The following is a description of a gene set: from publication Chen Y, Wang X (PMID 31504780) Human Gene Set: MIR30E_3P Genes predicted to be targets of miRBase v22 microRNA hsa-miR-30e-3p in miRDB v6.0 with MirTarget v4 prediction scores > 80 (high confidence targets). species: Homo sapiens, and this is the list of marker genes: EMC4, P2RY1, RALGPS2, EGR1 (NCBI Gene Id 1958), NKRF, DIP2B, TRMT10B, CCN3, RBM7, DLST, MYO5A, ZCCHC14, CNPY2, INTS8, SASS6, CEP350, ROCK2, PALS2, PDK4, GTPBP4, SUB1, SLC12A1 (NCBI Gene Id 6557), SEMA3C, ZNF827, TEAD1, SP3, SNX18, RNF217, NSL1, SLC6A3, SAMTOR, RCN2, ATRN, ARL11, EP300, CHMP1B, SESTD1, KANSL1L, NBEAL1, GUCY1A2, HS3ST5, ZNHIT6, CAPRIN1, FGF7, KLHL11, ARF6, SMG1 (NCBI Gene Id 23049), ZNF35, CENPL, UFSP2, PIAS2, PTPN3, BCCIP, RFK, ARHGAP28, ZNF138, ACTR2, EPGN, MAGT1, MAP3K4, ETNK1, GGH, CHCHD4, STIM2, CDC73, CCDC80, GOSR1, CALCA, KLHL5, PAG1, PIAS1, FXR1, CDKL5, TXLNB, RNF216, RYR3, HSPA5, MSR1, SLITRK3, AR, PCLO, LSS, TMPRSS11D, PDXDC1, SYNRG, SH3GL3, YTHDF3, TPK1, BRD8, LPGAT1, RNF141 (NCBI Gene Id 50862), ARID4A, SLC36A4, CACYBP, YPEL5, APC, DEUP1, ATP11C, PCSK5, PHF24, CAST, CHURC1, ZNF704, SPIRE2, SYNJ2, GALNT1, SERTAD2, HS3ST1, SNRK, ZNF280B, FCHO2, HMGN4, DBT, TLK2, MNT, DAZ2, GBP1, PRDM10, PANK3, ZDHHC21, EPAS1, VCPIP1, UBE2J1, YWHAE, RIF1, DNAJB4, MED12L, BCKDHB, ROR1, TPTEP2-CSNK1E, ZNF566, SLC25A33, CEP19, PRKAA2, IPCEF1, ZEB2, SLC10A7, SCAI, COCH, XPNPEP3, PSD3, DHFR, SLC35F3, CCDC186, TNFSF13B, B9D1 (B9 domain containing 1), USP38, LRCH1, DTNA, AKAP5, ITGA1, NAA25, SEC62, GM2A, RAB3IP, FAM98A, GABRG2, HYCC1, CWF19L2, SGMS2, CMKLR2, GNA12, CLDN14, KCTD16, ZNRF3, TENM1, UBR5, MTDH, SH3GLB1, PCDH17 (NCBI Gene Id 27253), CREBBP, TSPAN13, CAV1 (NCBI Gene Id 857), COL4A4, SLC27A6, ROBO1, NPAT, NEGR1, SOCS6, VANGL1 (VANGL planar cell polarity protein 1), CEP152, MCCC2, YARS2, KRBA2 (NCBI Gene Id 124751), MYO5C, PRDM11, SGCZ, DNAJB14, MYSM1, CCDC112, ATP9B, THOC2, TUSC3 (tumor suppressor candidate 3), VGLL3, NAPG, POU4F1, FAM20B, MTHFD2 (NCBI Gene Id 10797), CDKL2, NEMP1, GPR176, IL1B, SCAF4, IARS2, PHLDA1, NODAL, SLC5A3, MAP1B, RUNX1, TWNK, RTP4, AAK1, VCF1, USP1 (ubiquitin specific peptidase 1), GPRASP2, TRIM72, NTRK3, ELOC, NHS, SMAD2, RALA, OSBPL1A, TUBGCP5, FAM171B, OPRK1, COL12A1, STAU1, MEI4, PPM1B, SCAF11, TCP11L1 (NCBI Gene Id 55346), PSMD10, WDR44, KMT5B, TTPAL, CCDC184, ERAP1, ARMC1, SOS2, HDX, DNAI4, APOBEC3A, KMT2A, SH3D19, MEOX2, SOD2, NOX3, ASXL3, PRLR, UBXN2B (UBX domain protein 2B), NUFIP2, CSNK1G3, INO80C, PSIP1, PYROXD1, LCORL, EIF2AK1 (NCBI Gene Id 27102), CEP44, KRT6C, SEMA3E, SLC12A6, MFAP4, RAB8B, METTL4, MINDY2, C5orf24, HOXB7 (NCBI Gene Id 3217), FAR1, EOGT, KRT10-AS1 (NCBI Gene Id 147184), SNAP91, RANBP3L, ADA, GALNT7, NCOA7, BTNL9, TSHR, PMEL, TOB1, RBM45, STK38L, SBNO1, SH2D3A, MAP3K2, NOD1, HIRA, FAM114A2, OSBPL11, GPR158, ZNF430, ZBTB41, GATC, ANTXR2, PRPH2, ELAPOR2, PIGBOS1, SESN3, TCEAL6, CANX, TULP4, RGS7, CCKBR, FBXO22, LACTB, RGS7BP, ECM2, PLEKHH1, BRWD1, PTPN21, GPR137C, HMGA2, CSNK1E, ZFHX3, TOMM20, CALHM5, SRSF4, ZC3H14, PPP1R3A, SLC39A10, MRTFB, POGLUT3, CDKN1B, CCDC6, NPY2R, RNF6, TBC1D23, NAA16, TMEM47, NABP1, AP4E1, SELENOT, ZNF426, COLEC12, RELT, NPHP3, RUNX2, PHACTR2, IGF1, AKT3, TRIM33, ABHD5, RUNX1T1, GFPT1, LRRTM2, PDE12, PIK3AP1, PDK1, UBL3, CDC40, ZNF107, ADAMTS5, PTEN, ACBD3, SEMA6D, OTUD6B, SSR1, POU2F1, SYT14, DACH1, DNAJB9 (DnaJ heat shock protein family (Hsp40) member B9), EXTL2, ZBTB18, SUV39H2, TNRC6B, NR2C2, RB1, ZCCHC10, LRP8, EPS8, TPR (NCBI Gene Id 7175), MARS2, FBXL20, DOCK1, SYT4, DOP1B, ELK3, SLITRK6, SS18, UBE2G1, HOOK1, CREB1, NR3C1, CACNB4, C8orf44, FANCD2, PAIP2, GPR180, MRPL30, PIH1D2